The following is a description of a gene set: Human Gene Set: GOBP_POSITIVE_REGULATION_OF_CELL_CYCLE species: Homo sapiens Any process that activates or increases the rate or extent of progression through the cell cycle., and this is the list of marker genes: BRCA2, PLK4, WNT5A, VPS4B, EZH2, GEN1, MIR590, NSFL1C, ANAPC7, PIWIL2, PAFAH1B1 (platelet activating factor acetylhydrolase 1b regulatory subunit 1), PAGR1, CDK10, CCPG1, POC1A, TBX3 (NCBI Gene Id 91834), RAD51B, MAP3K20, CRNN, TCF3 (transcription factor 3), CCND2, PPP1R10, MEIS2, PAF1, STAT5A, MTBP, AURKC, MSX1, CPSF3, APP, LRP6, NUSAP1, MSX2, CSPP1, NCAPH, CDC25B, FGF8, MIR495, CDC6, EIF4EBP1, FOXA1, OVOL1, UBXN2B, BRD4, TGFB2, MIR208A, RAB11FIP3, TPR, BCL2L11, SKA3, STOX1, EXOC7, PTK6, SPAG5, IL1B, CUL4A (NCBI Gene Id 8451), IL1A, RAB11FIP4, FEN1, PRKCE, SLF1 (NCBI Gene Id 84250), SPAST, MIR520H, TGFB1, KNL1, CDC14B, FAM83D, OR1A2, KIF23, MEIOC, NDC80 (NDC80 kinetochore complex component), CHEK1, ECT2, SLC6A4, SFPQ, DAZL, MRGPRX2, MACROH2A1, ESPL1, MAD2L1, DDR2, SCAND3, RGCC, MDM2, ADAM17, CDC25C, ANAPC11, STXBP4, SMPD3, RRM2, ANAPC5, SIN3A, RACGAP1 (NCBI Gene Id 94651), NR2E1, C6orf89, PPP1R35, RRM2B, WNT10B, CHMP3, TMOD3, NR4A3, KAT5, YTHDC2, HSF1, NANOGP8, CCND1, HCFC1, NUDT16, GPSM2, NSMCE2, E2F7, CDK4, MAGEA4 (NCBI Gene Id 4103), ASNS, LSM10, RB1, ZNF16, MIR372, MIR21, MAP3K7, PLCG2, RAD51C, NCAPD2, EIF4E, RAB11A, INS, CDC16 (cell division cycle 16), ANXA1, SVIL, PLCB1 (NCBI Gene Id 23236), TBX2, LEF1, SPHK1, PLSCR1, CDC14A, BECN1, RPS6KB1, TP63, AKT1 (NCBI Gene Id 207), MIR29A, TAS2R13, CUL4B, FGFR1, INO80, EDN3, KMT2E, SMC6, CDC42, WIZ, HNRNPU, TAL1, STIL, STRA8, STAT5B, RDX, CDC7, NUPR1, MIR519D, OPN1LW, PBX1, CCDC57, CD28, DMRT1, MIR221, HOXA13, CCNE2, CDC14C, OR2A4, USP2, DTL, NCAPH2, MTA3, MIR26B, RBM46, PDGFB, ASCL1, DDRGK1, SRPK2, RARA, ARF6, CDK1, INCENP, DRD3, CXCR5, DLGAP5, PSMD10, CDCA5, KLHL18, CCNY, MAD1L1, FBXO5, WNK1, DUSP3, CYP1A1, NPM2, MAPK15, RHNO1, SMOC2 (NCBI Gene Id 64094), RAD21, CUL3, SOX15, PKN2, MAD2L1BP, CDC73, CENPV (NCBI Gene Id 201161), RAD51AP1, RANBP1, NCAPG2, MEPCE, MBLAC1, SMARCD3, PKP3, NEUROG1, LGMN, MARK4, SMC5, DYNC1H1 (dynein cytoplasmic 1 heavy chain 1), SKA1, BUB1, CALR, CDC23, AIF1 (allograft inflammatory factor 1), CITED2, DYNC1LI1, TBX20, UBE2C, IGF2, GIPC1, ZPR1, MEIOSIN, TGM1, RAD18, FGF10, DDX11, DBF4B, ADAMTS1, USP19, LSM11, NKX3-1, MIR222, KIF3B, SMC4, TRIM21, TAS1R2, RXFP3, PRAP1, PIM1, UBE2B, OOEP, FGFR2, AURKB, LRP5, OPN1MW (opsin 1, medium wave sensitive), SH2B1, SIRT2, RPTOR, KIF14, MIR515-1, PRKCA, DYRK3, EREG, UBE2E2, BTC, PKP4 (NCBI Gene Id 8502), EGF, CCND3, SLF2 (SMC5-SMC6 complex localization factor 2), NCAPD3, ATAD5, PRDM9, EGFR, TRIM32, ATRX, TGFA, DYNLT3, EDN1, SMC2, ANKRD31, RPS15A, CENPJ, PTENP1-AS, PHOX2B, ABL1 (ABL proto-oncogene 1, non-receptor tyrosine kinase), RAD23A, RRM1, DRD2, DDX3X, EPGN, KIF20B, INSR, CDC25A, CEP295, MAP10, TERT, FNTB, CEP120, MIR520A, KAT2B, TTL, RHOA, ANKRD17, WNT4, DBF4, CHEK2, SSTR5, MIR214, PDGFRB, CDCA8, PHIP, HES1, FOXG1, XRCC3, NUP62, E2F8, EIF4G1, CIT, NUMA1, NPM1, NPR2, LFNG, BIRC5, CCDC15, USP22, KCNA5, PTPN11, CCNB1, RCC2, NCAPG, PLRG1, SASS6, OPN1MW2, GLI1, CCNE1, TFDP1, HSPA2, TNF, IGF1, SHB, POLDIP2, POC1B, CDC20, AURKA, PROX1, ROCK2 (Rho associated coiled-coil containing protein kinase 2), MED1 (NCBI Gene Id 9327), IL10